Given this list of marker genes GJA1, PANX3, GJC2, GJA3, GJA10, GJB1, GJE1, GJB4, GJD3, GJA8, GJD4, GJB5, CCN3, GJB6, GJC1, GJA9, GJD2, SPECC1L, GJA5, GJC3, TJP1, PANX1, CALB2, GJA4, DBN1, GJB7, GJB3, GJB2, SGSM3, DSC1, here is a description of the gene set: Human Gene Set: GOCC_GAP_JUNCTION A cell-cell junction composed of pannexins or innexins and connexins, two different families of channel-forming proteins. studied in species Homo sapiens